The following is a description of a gene set: Mouse Gene Set: GOBP_ERYTHROCYTE_DEVELOPMENT species: Mus musculus The process whose specific outcome is the progression of an erythrocyte over time, from its formation to the mature structure., and this is the list of marker genes: Alas1, Nemp1, Bpgm, Adgrf4, Tal1, Ercc2 (NCBI Gene Id 13871), Ankle1, Hba-a1, Rhd, Rps6, Jmjd6, Maea, Rhag, Hbb-bs, L3mbtl3, Brd1, Med1, Adgrf5, Bloodlinc, Rac2, G6pd2, Bcl6, Slc25a40, Cited2, Rac1, Slc11a2, Slc4a1, Gm15915, Abcb10, Klf2, Epb42, Tmod3, Klf1, Lyar, Fam210b, Sox6, Alas2, Srf, Trim58, Epo, Flvcr1, Diaph3, Hdac6, Arid4a, Sh2b3 (NCBI Gene Id 16923), Pla2g10, Gata1 (GATA binding protein 1), Ank1, G6pdx, Hba-a2, Bap1, Heatr3, Ptbp3, Dmtn, Hba-x, Zbtb7a, Nckap1l